The following is a description of a gene set: Catalysis of the transfer of an acetyl group to a carbon atom on the acceptor molecule. species: Homo sapiens Human Gene Set: GOMF_C_ACETYLTRANSFERASE_ACTIVITY, and this is the list of marker genes: HADHB, ACAT1, ACAA2, HADHA, GCAT, ACAT2, ACAA1